Given this list of marker genes SMAD4, NODAL, APELA, EOMES, BMPR1A, FGF8, ZFP36L1, LHX1, SSBP3, here is a description of the gene set: Human Gene Set: GOBP_MESENDODERM_DEVELOPMENT studied in species Homo sapiens The process whose specific outcome is the progression of the mesendoderm over time, from its formation to the mature structure. In animal embryos, mesendoderm development gives rise to both mesoderm and endoderm tissues.